The following is a description of a gene set: Mouse Gene Set: GOBP_INTERLEUKIN_12_PRODUCTION The appearance of interleukin-12 due to biosynthesis or secretion following a cellular stimulus, resulting in an increase in its intracellular or extracellular levels. species: Mus musculus, and this is the list of marker genes: Foxp1, Tlr6, Flt3, Il17a, Plcb1, Pibf1 (NCBI Gene Id 75821), Cd47, Il10, Traf6, Ido1, Acp5, Nod2, Unc93b1, Tlr4, Il16, Tnfsf9, Scimp (SLP adaptor and CSK interacting membrane protein), Tigit, Lep, Laptm5, Mapk11, Nlrc3, Ifng, Ccl19, Hmgb1, Slamf1, Prkcd, Il12b, Ltb, Tlr9, Tnfsf4, Irf1, Lilra5, Hspd1, Defb25, Arrb2, Cmklr1, G6pdx, Thbs1, Mast2, Syk, Cd40lg, Tlr2, Rela, Rel, Isl1, Jak3, Tnfsf18, Irak3, Il23a, Cd36 (CD36 molecule), Tirap, Mapk14, Irf8, Il23r, Mdk, Nfkb1, Ccr7, C1qbp, Plcg2, Cd40, Tlr8, Tlr3, Clec7a, Mefv, Ager, H2-M3